Given this list of marker genes Lmf1, Lpl, Pcsk5, Gpihbp1, Lipc, Pcsk6, Lmf2, Furin, Angptl4, Angptl3, Angptl8, here is a description of the gene set: Mouse Gene Set: REACTOME_ASSEMBLY_OF_ACTIVE_LPL_AND_LIPC_LIPASE_COMPLEXES studied in species Mus musculus Assembly of active LPL and LIPC lipase complexes